The following is a description of a gene set: studied in species Homo sapiens Human Gene Set: GOBP_SYNAPTIC_VESICLE_TRANSPORT The directed movement of synaptic vesicles., and this is the list of marker genes: CTNNB1, BORCS5, AP3M1, PRKN, SNAPIN, AP3D1, BLOC1S5, LIN7C, BLOC1S4, BLOC1S2, AP3S1, KIF5A, BLOC1S6, LRRK2, BLOC1S1 (NCBI Gene Id 81990), AP3B1, AP3S2, AP1G1, AP3B2, SNCA, MX1, KIF5B, RAB3A, PDZD11, BLOC1S3, KIFC2, CDK5, TOR1A, DNM3, AP3M2, LIN7B, PINK1, SLC2A4, DNM1, RAB27A, LIN7A, SPG11, SYNJ1, DTNBP1, MX2, KIF1B, TMEM230, DNM2, KIF5C, MAP2, BTBD8, TRIM46